Given this list of marker genes MACC1, CAP1 (cyclase associated actin cytoskeleton regulatory protein 1), ERC2, CYBRD1, CCPG1, GABRB2, FJX1, PARD6B, ZNF235, TAB2, PDK3, RAB10, PPM1E, TMEM169, SERPINE1, SERTAD4, EPHA7, PBX2, FRS2, PALM2AKAP2 (NCBI Gene Id 5561), ZCCHC14, TICAM1, TENM2, SCN8A, LIN28B, MEX3C, ERMP1, CHRFAM7A, YPEL2, BTG2, RNF111, ESRRG, CCDC107, GOLPH3L, CACNA1A (calcium voltage-gated channel subunit alpha1 A), PLCB1, CTBP1, ARID1A, TFAP2D, KMT5A, TRIM49C, SERTM1, PLEKHA3, TRIM49D1, BAZ2B, PHEX, TMEM9B, GPD2, RHBDL2, OR2C3, HAS3, LRRN3, IL6ST, KDM5A, PRSS35, ANKUB1, AFF4, DDX59, CAPN14, ZFAND3, ILF2, EP300, FREM2 (NCBI Gene Id 341640), TMEM178A, OBI1, ETV1, LPP, CDON (NCBI Gene Id 50937), ZSWIM4, CNBD2, EHMT1, RDX, LARP1, STAG2, PIF1, FAM83B, FGF11, ARHGEF28 (Rho guanine nucleotide exchange factor 28), SSBP3 (NCBI Gene Id 55126), SHROOM4, RPS6KB1, FAM20B, RAP2A, ZNF554, WDFY1, ACTN1, ADD2, TRIM48, TADA2A, SRSF10, ABCC6, ZNF692, PAFAH1B1, ZNF716, HECW1, RAB27A, TRIM49 (tripartite motif containing 49), FAM81A (family with sequence similarity 81 member A), TRIOBP, IRX1, XIAP, LIPA, PPIL3, ZFP91, MPLKIP, ADAT2, SYT1 (synaptotagmin 1), TRIM49D2, ZNF484, DCP2, TAF4 (TATA-box binding protein associated factor 4), here is a description of the gene set: from publication Chen Y, Wang X (PMID 31504780) Human Gene Set: MIR2355_3P studied in species Homo sapiens Genes predicted to be targets of miRBase v22 microRNA hsa-miR-2355-3p in miRDB v6.0 with MirTarget v4 prediction scores > 80 (high confidence targets).